The following is a description of a gene set: species: Homo sapiens Monocyte-derived dendritic cells (DC) and macrophages (MΦ) generated in vitro from the same individual blood donors were exposed to five different pathogens, and gene expression profiles were assessed by microarray analysis. Responses to Mycobacterium tuberculosis and to phylogenetically distinct protozoan (Leishmania major, L. donovani, Toxoplasma gondii) and helminth (Brugia malayi) parasites were examined, each of which produces chronic infections in humans yet vary considerably in the nature of the immune responses they trigger. from publication Chaussabel D, Semnani RT, McDowell MA, Sacks D, Sher A, Nutman TB (PMID 12663451) Genes down-regulated in comparison of macrophages versus macrophages exposed to T. gondii. Human Gene Set: GSE360_CTRL_VS_T_GONDII_MAC_DN, and this is the list of marker genes: TMEM41B, SF1, ZNF124, PFDN4 (prefoldin subunit 4), CXCL8, CCNE1, TNF, TENT4A, RIOX2, PHLDB1, PDE10A, LRP3, ZNF592, NELFA, SREBF1, TOMM34, HNRNPH1, UBE2V2, DLEC1, VTI1B, ME3, NPC1, DLC1, CLTA, RELN, PLK2, CHST7, LSM4, HNRNPR, BAG2, ABCB9, OASL, MNT, HSD17B3, RGS16, NRG1, IQSEC2, ARR3, PBX2, FOS, WEE1, NBL1, FMNL1, AKAP9, CYC1, GTF2A2, INPP5B, DTNA, SEC22B, HMGA1, KIF5A, CRYBA4, AKAP17A, GPR15, CST6, SLC5A6, CERS6, FLAD1, TICAM1, TEX30, PGM1, SLC43A1, RALY, ITGB3BP, DKC1, UNC93A, LAMA3, ESRRA, GP1BB, FOXO1, CD83, TSR3, S100A10 (NCBI Gene Id 6281), SRGN, DPEP1, ADAM8, CAMSAP2, TNFRSF9, RUVBL1, COX10, PCGF3, KDM2A, METTL13, GNA15, TM2D1, EZR, CCR5, ATP5MC3, TSPAN3, BCL2L1, PYGM, CDIPT, EML3, RPS6KA5, SULT1C2, SLC2A1, DVL1, MCF2L, PFDN1, USPL1, ALG3, CSF2RB, ZNF785, UBE3C, H2AZ2, GNA11, PRPF3, GBP2, NR0B2, COG5, SPINK4, TP53BP2, RCC1, POLD2, ID3, GPR183 (G protein-coupled receptor 183), NRTN, IFIT1, FAM171A1, MBD3, CCT7, CDK13, SLC14A1, RCAN1, GOSR2, NTF3, COL19A1, MAPKAPK2, KIF1B, PPFIA3, HGS, GAL, FPGT, CCT5, CDK16, MUC6, CNTN2, RNASE4, DYNC2LI1, USP19, RCN2, PSMC3IP, RAD9A, SCGN, FOSL2, ADARB1, BCAS2, HARS1, UTRN, PTPRCAP (protein tyrosine phosphatase receptor type C associated protein), H6PD, NONO, GRPR, LETMD1, MAPK7, RBM4, IFNGR2, BRCA2, FLNB, TRAF5, ATP2B3, TRIB1, PNO1, IKZF1, CRLF3, PLEKHA6, BCAT1, ZFP36, ATP1B2, PTGER2, SDC2, REM1, MTHFD1, TNFSF12, APBB3, G0S2, MSH2, CXCL3, AMHR2, LAMB3 (NCBI Gene Id 3914), KDM5C, BAG1, SP3, AK2, IKBKG, PCBP2, SLBP, ODC1, PLP2, ZPR1, ELL2, UPP1, SCN9A, PTN, ERLIN1, H2BC13, GAB1, CALM1